The following is a description of a gene set: studied in species Mus musculus Reactome Pathway: Signaling by VEGF electronically inferred by orthology from the curated human pathway part of: Signaling by Receptor Tyrosine Kinases This event has been computationally inferred from an event that has been demonstrated in another species.<p>The inference is based on the homology mapping from PANTHER. Briefly, reactions for which all involved PhysicalEntities (in input, output and catalyst) have a mapped orthologue/paralogue (for complexes at least 75% of components must have a mapping) are inferred to the other species., and this is the list of marker genes: Pdpk1, Mapk12, Cav1 (NCBI Gene Id 12389), Cyba, Them4, Rasa1, Bcar1 (breast cancer anti-estrogen resistance 1), Prkca, Jup, Ctnnb1, Pxn, Cdc42, Hspb1, Pak3, Pik3r2, Vegfa, Ncf2, Cyfip2 (NCBI Gene Id 76884), Vegfb, Mapk13, Fyn, Pgf, Prkaca, Flt4, Cdh5, Pik3cb, Shc2, Wasf3, Calm1, Vegfd, Crk, Mapk11, Prkacb, Mapk14, Vav1, Wasf1, Flt1, Ptk2, Hras, Axl, Rictor, Vegfc, Shb (src homology 2 domain-containing transforming protein B), Ncf1